The following is a description of a gene set: Genes predicted to be targets of miRBase v22 microRNA hsa-miR-1909-3p in miRDB v6.0 with MirTarget v4 prediction scores > 80 (high confidence targets). from publication Chen Y, Wang X (PMID 31504780) studied in species Homo sapiens Human Gene Set: MIR1909_3P, and this is the list of marker genes: PBXIP1 (PBX homeobox interacting protein 1), FBXL18, SH3PXD2A, FOXO4, THEM5, NFIC, STK35, EFHD2, NPTX1, LHPP, EPHA2, PYCR3, PSD3, CLK2, RPP25, MTCL2, TTYH3, ZNFX1, NR6A1, PHF21A, UBE2M, MYD88, SEMA3F, PPP1R9B, MPP2, MTRF1L, RAB1B, IP6K2, LRRC20, TSKU, PLPPR2, CTDSP1, HSP90B1, PDXK, CANX, DOC2B, NFAM1, E2F7, RCBTB2, OTOP2, COG6, FBXL19, RPP14, IGF1, DCHS1, CARMIL1, PLCXD3, GRID2, SP7, UPP2, ZFP41, WDTC1, MEX3A, MAP1A, HTR4, ATP9B, PRRT2, ADGRA1, KIF21B, ZNF710, DAB2IP, PHAF1, DLC1, CDK16, NIBAN3, REEP4, ACTMAP, ORMDL3, CACNB3, CREB3L2, SPINDOC, EFHC2, ARHGDIG, GDPD5, SNX21, TNRC6B, ORC5, B9D1, SNX33, DEDD2 (death effector domain containing 2), MGRN1, CAMKV, RAB5B, ELF4, PMEPA1, DDR1 (NCBI Gene Id 780), NFASC (neurofascin), ZMYM6, SIGMAR1 (NCBI Gene Id 80768), TSPAN9, TSPAN33, TGFBR2, NFATC2, GPR62, EIF2B5, STX1B, ZCCHC24, FGF1, RYBP (RING1 and YY1 binding protein), POLR3C, DHODH, RAPGEFL1, ATG9A (autophagy related 9A), PRND, MARK2, ZMAT2, RNF157, ATP12A (NCBI Gene Id 479), CHMP6, MAZ, FHL3, C10orf90, UBTF, ACTR1B, CALB2, SNURF, GSKIP, AHDC1, FAM131C, RTL8C, BAK1, RBM42, ITPKB, CNOT9, UGT2B28, TSPAN7, SPTBN4, HM13, SNRPN, ITGAL, INO80, KSR2, MEF2D, KCTD16, GRAMD1B, NTNG2, CAMK2G, DPPA4